Given this list of marker genes SRSF1, VRK1, EXOSC8, PSMD6, MCM5, NUP50, CBX3, ANP32B, DHX15, PA2G4, SNRPD1, SUZ12, FEN1, SMC3, SNRPE, VBP1, ETFA, USP1, SLBP, COPS3, RAD21, U2SURP, RRM1, MRPL35, RPA1, NDC80, SRI, NUSAP1, SERBP1, ANP32E, METTL5, METAP2, CENPF, DEK, NUP153, HMGB2, USP14, MCM3, MCM2, SMC4, IFT25, SRSF3, PRPS1, PTGES3, HNRNPA3P1, HAT1, CHCHD3, EIF2S1, SNRPG, RBMX, here is a description of the gene set: Neighborhood of HAT1 histone acetyltransferase 1 in the GNF2 expression compendium Neighborhood of HAT1 studied in species Homo sapiens Human Gene Set: GNF2_HAT1